The following is a description of a gene set: An immune response mediated by a T cell triggered in response to the presence of a tumor cell. studied in species Mus musculus Mouse Gene Set: GOBP_T_CELL_MEDIATED_IMMUNE_RESPONSE_TO_TUMOR_CELL, and this is the list of marker genes: Hmgb1, Slc22a13, Fbxo38, Mr1, Il4i1, Ywhag, Ahr, Ufl1, Muc4 (mucin 4), Klhl22, Cd24a, Cd274, Pdcd1, Prkaa1, Hspd1